Given this list of marker genes Dpp4, Ffar1, Gip, here is a description of the gene set: This event has been computationally inferred from an event that has been demonstrated in another species.<p>The inference is based on the homology mapping from PANTHER. Briefly, reactions for which all involved PhysicalEntities (in input, output and catalyst) have a mapped orthologue/paralogue (for complexes at least 75% of components must have a mapping) are inferred to the other species. part of: Incretin synthesis, secretion, and inactivation studied in species Mus musculus electronically inferred by orthology from the curated human pathway Reactome Pathway: Synthesis, secretion, and inactivation of Glucose-dependent Insulinotropic Polypeptide (GIP)